The following is a description of a gene set: studied in species Homo sapiens Any process that modulates the frequency, rate or extent of L-glutamate import into a cell. Human Gene Set: GOBP_REGULATION_OF_L_GLUTAMATE_IMPORT_ACROSS_PLASMA_MEMBRANE, and this is the list of marker genes: TNF, ITGB1, ATP1A2, SLC17A8, ARL6IP5, SEPTIN2, PER2, PSEN1, ARL6IP1